The following is a description of a gene set: species: Mus musculus The removal of an acetyl group from a protein amino acid. An acetyl group is CH3CO-, derived from acetic acid. Mouse Gene Set: GOBP_PROTEIN_DEACETYLATION, and this is the list of marker genes: Hdac3, Tppp, Fnta, Mapt, Prkaa1, Zzz3, Prkaa2, Tada3 (transcriptional adaptor 3), Tada2a, Bex6, Flna, Sgf29, Nek3, Ndn, Ncor2, Sirt1 (sirtuin 1), Fry, Sirt2, Sirt5, Sirt4, Hdac4, Kat14, Brms1, Ifng, Hdac6, Hdac7, Bex4, Sirt3, Wdr5, Hdac1 (NCBI Gene Id 630524), Dr1, Mbip, Ndst1, Kat2a, Sirt6 (sirtuin 6), Hdac2, Sirt7, Nnmt, Ep300, Yeats2, Hdac9, Ccar2